The following is a description of a gene set: Human Gene Set: IIZUKA_LIVER_CANCER_EARLY_RECURRENCE Genes down-regulated in hepatocellular carcinoma (HCC) tumors with higher risk of early intrahepatic recurrence. The single up-regulated gene (GenBank Accession=AC000063) has been excluded from the signature. studied in species Homo sapiens from publication Iizuka N, Oka M, Yamada-Okabe H, Nishida M, Maeda Y, Mori N, Takao T, Tamesa T, Tangoku A, Tabuchi H, Hamada K, Nakayama H, Ishitsuka H, Miyamoto T, Hirabayashi A, Uchimura S, Hamamoto Y (PMID 12648972) BACKGROUND: Hepatocellular carcinoma has a poor prognosis because of the high intrahepatic recurrence rate. There are technological limitations to traditional methods such as TNM staging for accurate prediction of recurrence, suggesting that new techniques are needed. METHODS: We investigated mRNA expression profiles in tissue specimens from a training set, comprising 33 patients with hepatocellular carcinoma, with high-density oligonucleotide microarrays representing about genes. We used this training set in a supervised learning manner to construct a predictive system, consisting of genes, with the Fisher linear classifier. We then compared the predictive performance of our system with that of a predictive system with a support vector machine (SVM-based system) on a blinded set of samples from 27 newly enrolled patients. FINDINGS: Early intrahepatic recurrence within 1 year after curative surgery occurred in 12 (36%) and eight (30%) patients in the training and blinded sets, respectively. Our system correctly predicted early intrahepatic recurrence or non-recurrence in 25 (93%) of 27 samples in the blinded set and had a positive predictive value of 88% and a negative predictive value of 95%. By contrast, the SVM-based system predicted early intrahepatic recurrence or non-recurrence correctly in only 16 (60%) individuals in the blinded set, and the result yielded a positive predictive value of only 38% and a negative predictive value of 79%. INTERPRETATION: Our system predicted early intrahepatic recurrence or non-recurrence for patients with hepatocellular carcinoma much more accurately than the SVM-based system, suggesting that our system could serve as a new method for characterising the metastatic potential of hepatocellular carcinoma., and this is the list of marker genes: SGK1, HLA-DRA, VIM, TRIM22, REL, LAPTM5, MEF2C, CCND2, TNFAIP3, PDGFRA, DDX17